The following is a description of a gene set: studied in species Homo sapiens Human Gene Set: GOBP_REGULATION_OF_RUFFLE_ASSEMBLY Any process that modulates the frequency, rate or extent of ruffle assembly., and this is the list of marker genes: NLGN1, P2RX4, EVL, EPS8, SH3YL1, RDX, KANK1 (KN motif and ankyrin repeat domains 1), COBL, RAC1, ICAM1, RHOG, PLEKHM1, EPS8L3, STAP1, CAV1, CORO1C, PFN1, ABI3, P2RY12, DEF8, TACSTD2, CARMIL2, EPS8L1 (EPS8 signaling adaptor L1), FAM98A, ARHGAP24, NDEL1, PFN2, WDPCP, USP17L2, EPS8L2, RCC2, HRAS